The following is a description of a gene set: Human Gene Set: REACTOME_STAT3_NUCLEAR_EVENTS_DOWNSTREAM_OF_ALK_SIGNALING STAT3 nuclear events downstream of ALK signaling studied in species Homo sapiens, and this is the list of marker genes: EP300, HDAC1, DNMT1, HIF1A, IL2RG, CD274, PRDM1, SIN3A, STAT3, HDAC3, HDAC2